The following is a description of a gene set: studied in species Mus musculus Reactome Pathway: Interferon Signaling electronically inferred by orthology from the curated human pathway This event has been computationally inferred from an event that has been demonstrated in another species.<p>The inference is based on the homology mapping from PANTHER. Briefly, reactions for which all involved PhysicalEntities (in input, output and catalyst) have a mapped orthologue/paralogue (for complexes at least 75% of components must have a mapping) are inferred to the other species. part of: Cytokine Signaling in Immune system, and this is the list of marker genes: Ifna15, Tubb2b, Tuba3b, Camk2b, Tarbp2, Tuba1b (tubulin, alpha 1B), Gbp2, Ifna14, Tuba1a, Ifna13, Tuba8, Ptpn2 (protein tyrosine phosphatase, non-receptor type 2), Mapt, Npm1, Ppp2r5a, Fnta, Tuba1c, Tubal3, Socs1, Ptpn6, Eif4a1, Ifi44, Oasl1, Kpna1, Tubb4a, Tubb6 (tubulin, beta 6 class V), Uba7, Tuba4a, Ilf2, Flnb, Ube2n, Ifna4, Hspa1l, Faap20, Fance, Irf9 (NCBI Gene Id 16391), Ppp2r1b, Socs3, Ifna12, Ilf3, Cdk1, Cenps, Ifngr1, Fancb, Ifnar1, Ifng, Gbp5, Ppm1b, Ifnb1, Ptpn1, Mapk3, Rps27a, Mavs, Ifngr2, Ifna16, Arih1, Ubb, Eif4a2, Faap100, Tyk2, Dus2, Ube2e1, Snca, Pde12, Ifnab, Fancc, Ikbkb, Rigi, Ifna1, Sumo1, Fancg, Hspa2, Kpnb1, Tubb4b, Ifna9, Map2k6, Irf3, Eif4e3, Trp53, Cenpx, Becn1